The following is a description of a gene set: species: Homo sapiens The process whose specific outcome is the progression of a pacemaker cell over time, from its formation to the mature state. Pacemaker cells are specialized cardiomyocytes that are responsible for regulating the timing of heart contractions. Human Gene Set: GOBP_CARDIAC_PACEMAKER_CELL_DEVELOPMENT, and this is the list of marker genes: TBX3, MAML1, NKX2-5, SHOX2, TBX18, BVES (NCBI Gene Id 11149), BMPR1A, TBX5, ISL1